The following is a description of a gene set: Hyperactive stretch reflexes of muscles that move proximal joints (elbow, knee). Proximal hyperreflexia Human Gene Set: HP_PROXIMAL_HYPERREFLEXIA studied in species Homo sapiens, and this is the list of marker genes: MTPAP, SPTAN1, ALDH18A1, SACS, PNPLA6, SDHB, SDHA, NONO, KLC2, IBA57, SDHD, HEXB, SDHAF1, ATP13A2, SIGMAR1, ANO10, COX4I1, HARS1, FLRT1, ARL6IP1, PGM3